The following is a description of a gene set: Any process that modulates the frequency, rate or extent of hydrogen peroxide-mediated programmed cell death. Mouse Gene Set: GOBP_REGULATION_OF_HYDROGEN_PEROXIDE_MEDIATED_PROGRAMMED_CELL_DEATH studied in species Mus musculus, and this is the list of marker genes: Hk3, Ddr2, Endog, Ep300, Pink1, Foxo3, Trap1, Foxp1 (forkhead box P1), Rack1, Pawr, Hgf, Park7, Foxa1, Met